The following is a description of a gene set: Human Gene Set: GOMF_LIGASE_ACTIVITY species: Homo sapiens Catalysis of the joining of two molecules, or two groups within a single molecule, using the energy from the hydrolysis of ATP, a similar triphosphate, or a pH gradient., and this is the list of marker genes: UBE2L5, MT-ATP8, ACSM5, PCCA, LGSN, PCCB, ATP5PB, ACSL3, QARS1, FARSB, CARNS1, EPRS1, TARS2, MCCC2, RIMKLA, SUCLG1, ASS1, LRRC47, AARS1, ACSF3, NAE1, ATP5PD, AACS, ATP6V0C, DARS1, ACSM2A, DIP2A, NADSYN1, TTLL5, GATB, RIMKLB, LARS2, RARS1 (arginyl-tRNA synthetase 1), DARS2, MT-ATP6, TTLL2, SARS1, CTPS1, GMPS (NCBI Gene Id 8833), SLC27A6, ATP5MG, MCCC1, EARS2, QRSL1, UBA1, ATP5F1B, VARS1 (valyl-tRNA synthetase 1), SARS2, ATP5ME, TTLL13, UBA6 (NCBI Gene Id 55236), ACSM1, VARS2, GART, ATG7, HARS1, BTRC, SLC27A2, FARSA, TTLL3, ASNSD1, SAE1, SLC27A1, MDM2, TTLL11, DALRD3, TTLL10, ACACB, SLC27A4, CTPS2, UBA7, GARS1, TTLL9, ACSS3, DPH6, LIPT2, ATP5MGL, TPGS1, ACSM3, IARS1, IARS2, PAICS, LIG1, TTLL7, ATP5MF, MTHFD1, PC, KARS1, ATP5PF, GSS, TTL, UBA5, TTLL1, PFAS, ACSM4, NARS2, ATP5PO, MTHFD1L, ITCH, ACSM6, CAD, WARS2, RTCB, XRCC4, MID1IP1, TTLL6 (tubulin tyrosine ligase like 6), AARS2, SLC27A5, LIG4, AK3, TTLL4, ACSL5, YARS2, TTLL8, ACSS2, SUCLA2, ACSL4 (NCBI Gene Id 4426), ATP5F1A, ACSS1, FPGS, CARS2, SLC27A3, ATP5F1EP2, ATP5F1E, SUCLG2, NAPRT, RLIG1, TARS3, CARS1 (cysteinyl-tRNA synthetase 1), CPS1, PARS2, GHDC, MARS1, PPCS, WARS1, FARS2, CAPN3, RARS2, ATP5F1C, ACSL6, ADSS2 (NCBI Gene Id 159), GLUL, GCLM, RTCA (NCBI Gene Id 8634), LARS1, YARS1, ACACA, LIG3, ASNS, HARS2, AARSD1 (alanyl-tRNA synthetase domain containing 1), ACSBG1, ATP5F1D, UBA3, TTLL12, ADSS1, ACSL1, MARS2, ACSBG2, ACSM2B, GATC, MTHFS (methenyltetrahydrofolate synthetase), TRIM25, HLCS, UBA2, ACSF2, GCLC, MOCS3, AASDH, TARS1, NARS1